The following is a description of a gene set: The progression of the adenohypophysis over time from its initial formation until its mature state. The adenohypophysis is the anterior part of the pituitary. It secretes a variety of hormones and its function is regulated by the hypothalamus. Human Gene Set: GOBP_ADENOHYPOPHYSIS_DEVELOPMENT studied in species Homo sapiens, and this is the list of marker genes: FGF8, BMP2, GHRHR, SOX2, FGF2, DRD2, PROP1, PITX2, GATA2, GHRH, GSX1, HES1, POU1F1, WNT4, SLC6A3 (NCBI Gene Id 6531), LHX3